Given this list of marker genes Itgb1, Lamc1, Fktn, Large1, Lama1, Cav1 (caveolin 1, caveolae protein), Mmp11, Clasp2, Cav2, Ric8a, Lama2, Ntn4, Ext1 (exostosin glycosyltransferase 1), Prickle1, Fshr, Clasp1, Gas2, Pmp22, Phldb1 (NCBI Gene Id 213800), Col3a1, Pomt2, Lamb2, Nid1, Col4a1, Phldb2, Ramp2, Hpn, Ctss, Fermt1, Spint2, Plod3, Pomgnt1, Dag1, Fkrp, Lamb1, Col6a1, Megf9, Pxdn, Cma1, Flrt2, Hmcn1, Lamb3, Tfap2a, here is a description of the gene set: A process that is carried out at the cellular level which results in the assembly, arrangement of constituent parts, or disassembly of the basement membrane. species: Mus musculus Mouse Gene Set: GOBP_BASEMENT_MEMBRANE_ORGANIZATION